The following is a description of a gene set: from publication Sheth SS, Bodnar JS, Ghazalpour A, Thipphavong CK, Tsutsumi S, Tward AD, Demant P, Kodama T, Aburatani H, Lusis AJ (PMID 16607285) Cluster PAM5: genes changed exclusively in hepatocellular carcinoma (HCC) samples from 27 month old mice deficient for TXNIP. The molecular pathogenesis and the genetic aberrations that lead to the progression of hepatocellular carcinoma (HCC) are largely unknown. Here, we demonstrate that the thioredoxin interacting protein (Txnip) gene is a candidate tumor suppressor gene in vivo. We previously showed that the recombinant inbred congenic strain HcB-19 has a spontaneous mutation of the Txnip gene, and we now show that the strain has dramatically increased incidence of HCC, and that the HCC cosegregates with the Txnip mutation. Approximately 40% of the Txnip-deficient mice developed hepatic tumors with an increased prevalence in male mice. Visible tumors develop as early as 8 months of age. Histological analysis confirmed the morphology of HCC in the Txnip-deficient mice. Molecular markers of HCC, alpha-fetoprotein and p53, were increased in tumors of Txnip-deficient mice. The upregulation of p53 preceded tumor development; however, bromodeoxyuridine (BrdU) labeling of normal hepatic tissue of Txnip-deficient mice did not reveal increased cell proliferation. Finally, microarray analyses of tumor, non-tumor adjacent, and normal tissue of Txnip-deficient mice highlighted the genetic differences leading to the predisposition and onset of HCC. Our findings suggest that Txnip deficiency is sufficient to initiate HCC and suggest novel mechanisms in hepatocarcinogenesis. species: Mus musculus Mouse Gene Set: SHETH_LIVER_CANCER_VS_TXNIP_LOSS_PAM5, and this is the list of marker genes: Zbtb21, Smarcad1, Lamc2, Zfp474, Ldlrad4, Sema5a, Ctsj, Lce1d, Tcf3, Syncrip, Kcnj4, Igbp1, Fbxo33, Stk26, Bud31, Fjx1, Prl2b1, Tbx2, Aipl1, Neil3, Castor2, Rab3il1, Klk1b3, Bmp15 (bone morphogenetic protein 15), Cd8a, Jag1 (NCBI Gene Id 170642), Dppa2, Cabp1, Sorcs2, Rwdd3, Cd40, Fzd3, Nrk, Otud7a, Tnfrsf13c, Gpx6, Tti2, Ldhc, Cckbr, Slc1a3, Spz1, Clgn, Magea6, Hhip, Zpbp, Spock3, Kcnd3, Il7, Pappa, Pkib, Ip6k1, Kcnk4, Slamf1, Pi15, Dtd2, Ctc1, Zbtb45, Glipr2, Oprd1, Epyc, Slfn3, Iglv1, Mlph, Elavl4, Ngfr, Ceacam11, Fut1, Lrp2, Amot, Aqr, Pax9, Crygs, Polh, Dsc1, Taf7l, Srsf2, Naa11, Ncam1, Alg2, Ccdc43, Igf1r, Chst5, Cit, Akr1e1, Fgd4, Chn1, Tlr4, Ccr10, Rhoh, Ube2e3, Cklf, Sowaha, Mark4, Cd55os, Iapp, Itsn1, Apc2, Myh7, Orc2, H2-Ob (NCBI Gene Id 15002), Sp4, Pcdhb20, Hand1, Mitf, Mup4, Runx1, Mcub, Adam3, Smc1b, Elovl4, Miga2, Rnf17, Cela3b, Mapk13